The following is a description of a gene set: from publication Sheth SS, Bodnar JS, Ghazalpour A, Thipphavong CK, Tsutsumi S, Tward AD, Demant P, Kodama T, Aburatani H, Lusis AJ (PMID 16607285) The molecular pathogenesis and the genetic aberrations that lead to the progression of hepatocellular carcinoma (HCC) are largely unknown. Here, we demonstrate that the thioredoxin interacting protein (Txnip) gene is a candidate tumor suppressor gene in vivo. We previously showed that the recombinant inbred congenic strain HcB-19 has a spontaneous mutation of the Txnip gene, and we now show that the strain has dramatically increased incidence of HCC, and that the HCC cosegregates with the Txnip mutation. Approximately 40% of the Txnip-deficient mice developed hepatic tumors with an increased prevalence in male mice. Visible tumors develop as early as 8 months of age. Histological analysis confirmed the morphology of HCC in the Txnip-deficient mice. Molecular markers of HCC, alpha-fetoprotein and p53, were increased in tumors of Txnip-deficient mice. The upregulation of p53 preceded tumor development; however, bromodeoxyuridine (BrdU) labeling of normal hepatic tissue of Txnip-deficient mice did not reveal increased cell proliferation. Finally, microarray analyses of tumor, non-tumor adjacent, and normal tissue of Txnip-deficient mice highlighted the genetic differences leading to the predisposition and onset of HCC. Our findings suggest that Txnip deficiency is sufficient to initiate HCC and suggest novel mechanisms in hepatocarcinogenesis. studied in species Mus musculus Cluster PAM1: genes up-regulated in hepatocellular carcinoma (HCC) vs normal liver tissue from mice deficient for TXNIP. Mouse Gene Set: SHETH_LIVER_CANCER_VS_TXNIP_LOSS_PAM1, and this is the list of marker genes: Nkapl, Tceal3, Leprotl1, Pla1a, Fam181b, Col4a5, Ggct, Ckap4 (cytoskeleton-associated protein 4), Spon2, Srd5a2, Sema4b, Tgm2 (NCBI Gene Id 21817), Crisp1, Krtcap2, Col4a1, Cklf, Mtmr2, Ddit4, Aipl1, Slc2a3, Hnrnpab, Rell1 (RELT-like 1), Plpp2, Tuba3a, Trpc6, Plin3, Fpr3, Bco1, Hip1r, Avpi1, Tmem167, Lss, Clca1, Cyp27b1, Aig1, Fbxo6, Sirpa, Coq8b, Haus7, Krt18, Plau, Coro1c, Nek6, Trim2, Sectm1a, Ccm2, Marveld2, Twf2, Srd5a3, Ubd, Psph (NCBI Gene Id 19196), Tfrc, Vasn, Psmc1, Bok, Mansc1, Ikbke, Arl2bp, Epb41l4a, Acot10, Cd9 (NCBI Gene Id 12527), Cd34, Nebl, Rbbp7, Clcnka, Apex2, Rhbdf1, Mmut, Pvr, Mfge8, Klhdc2, Ano10, Stx18, Sstr2, Klra2, Scamp5, Arf3, Casp1, Prss23, Cd320, As3mt, Igsf8, Spic, Gpc6, Iqgap3, Phgdh, Trib3, Klf6, Apc, Ptpre, Sh3bgrl3, Pdzd11, Tuba1b, Abcg5, Shroom3, Defb1, Kcne3, Rem2, Anxa4, Col3a1, Ehmt2, Cep55, Napsa, Hes1, Tor2a, Top2a, Tspan33, Atp6v0a1, Mapk8ip1, Snca, Ercc3, Tff2, Padi4, Nlrp5, Tesc, Sidt1, Lypd3, E2f3, Mta3, Rp2, Tcf4, Mtf1 (NCBI Gene Id 17764), Ier5, Rnase2b, Atf4, Stmn1, Hexa, Mtap, Ercc8, Ctps1, Prkca, 5031439G07Rik, Loxl1, Cdk5r2, Ifngr1, Lmna, Limk1, Nopchap1, Osgin1, Dnajc12, Ackr3, Fam83g, Slc41a3 (NCBI Gene Id 71699), Cdca5, Nedd9, Apln, Nek2, Bcl2l11, Agfg1, Pigc, Gusb, Col4a3, Slc6a8, Ctps2, Pea15a, Pitpnm1, Mpp1, Dbndd2, Bicc1, Rrbp1, Itm2c, Dynll1, Phip, Cd24a, Etv5, Pcgf6, Nrgn, Tnk2 (tyrosine kinase, non-receptor, 2), Msl2, Klhl13, Arf6, Rph3a, Rftn2, Cdc20, Klc3, Ube2s, Rnd3, Lyve1, Smc4, Rarg, Slc48a1, Lpl, Ces2g, Tgfb2, Lox, Sh3gl3, Pafah1b3, Gngt1, Chka, Satb2, Dpp7, Vmn2r88, Abhd5, Itga3, Ildr1, Kif11, Scn1b, Itpr3, Entpd2, Ptpn21, Tubb4b, BC016579, Bcl10, Bsnd, Cldn1, Tmem41b, Rai14, Rpl12 (ribosomal protein L12), Cstb, F11r, Dck, Rflnb, Chchd5, Trp53rka, Nol11, Tpd52, Bicd1, Fam110c, Gnrhr, Fst, Degs2, 1700017B05Rik, Nkain4, Snx30, Alcam, Tjp2, Yap1, Fam3c, Nap1l1, Greb1, Pdlim7, Tpmt, Enc1, Sh3gl2, Enpp2, Vasp (NCBI Gene Id 22323), Sfxn4, Casp12, Mcm3, Atxn10, Cd151, Cyp4f16 (cytochrome P450, family 4, subfamily f, polypeptide 16), Bmal1, Scarb1, Abhd8, Reep5, Mat2a, Spire2, Slc22a22, Frrs1, Lhx8, Pycr1, Sox4, Jpt1, Kctd17 (potassium channel tetramerisation domain containing 17), Fktn, Nme6, Trib2, Cd2ap, Dnajc5b, Hipk1, Dhx9, Qtrt1 (NCBI Gene Id 70199)